The following is a description of a gene set: Stromal cell lines represent an exceptional tool to study the role on the microenvironment on hematopoietic stem cell (HSC) activity. We have compared the expression profile of HSC supportive vs non-supportive stromal lines generated from different hematopoietic tissues in the mouse, i.e the aorta-gonad-mesonephros (AGM) region, the fetal liver and the adult bone marrow, sequentially activated during development. In this study, six stromal lines were used with one HSC supportive and one non-supportive for each tissue (triplicate samples for each stromal line). We used Mouse Gene 1.0 ST microrrays in combination with GSEA and statistical analysis to identify lists of genes that segregate HSC supportive from non-supportive stromal lines. Genes up-regulated in the HSC supportive stromal cell lines. species: Mus musculus Mouse Gene Set: DURAND_STROMA_S_UP, and this is the list of marker genes: Adam8, Pdgfrb, Nrbp2, Ndrg1, Elfn1, Gas2, Npr3, Fam20a, Rnf150, Taf9b, Col3a1, Ltbp2, Depdc7, St3gal1, Cdkn2b, Sema3f, Nynrin, Adam12, Hspb8, Oasl1, Lpar4, Speg, Mmp15, Pxylp1, Col4a6, Dtx3l, 1700048O20Rik, Prrg1, Oxr1, Six1, Plekha2, Ctsh, Mmp23, Fabp7, Ivd, Lrig3, Stat1 (NCBI Gene Id 98183), Nxf3, Dync2i1, Pmvk, Il1r1, Gria3, Htra3, Car5b, Maged2, En1, Tiaf2, Serpinb6b, Tcf7l1 (transcription factor 7 like 1 (T cell specific, HMG box)), Bmper, Pde4d, Eif4e3, Mtss2, Rtp4, Ago4, Itgb3bp, Rbpms2, Lrp11, Osmr, Lhx9, Plekhg4, Pde1b, Chst1, Jak3, Smoc2, Rhobtb1, Galnt13, Plxna2, Il1rl1, Il15, Phospho1, Col6a2, Hoxc8, Syn1, Lrrc4c, Arhgef6, Mn1, Slc4a4, Fut8, Calcrl, Adgrl2, Duoxa1, Ubash3b, Slc43a1, Tfap2a, Porcn, Sulf2, Cdyl2, Gata3, Fam110b, Fzd1, Hoxb13, Ust, Rtkn2, Sox5, Inpp4b, Mest, Plxnd1, St6galnac2, Epn3, Ly6f, Zc2hc1a, Arhgef28, Ell2, Efna5, A4galt, Cyp26b1, B4galnt1, Mid2, Snai2, Ccn5, Cdkn1c, Zdhhc15, Sorcs2, Rac3, Notch4, Ptprf, Fgf10, Coro2a, Selenop, Ptn, Kbtbd7, Car13, Eda, Scn1b, Nes, Morc4, Lonrf3, Oasl2, Fzd8, Nudt14, Prkd1, St6gal1, Klra6, Atp10a, Gm57857, Dock3, Arc, Tbx20, Rb1cc1, Slc37a2, Capn6, Col1a1, Pear1, Pdlim4, Col1a2, Angel1, Tnfrsf23, Hykk, Myo1d, Prune2, Inf2, Emb, Dynap, Jup, Adamts2, Castor1, Dclk2, Onecut2, Rab3il1, Il18rap, Ifit1, Adam19, Rps6ka6, Rgs4, Tmem121, Plpp3, Lgalsl, Pde1a, Lamtor4, Rorb, Chst2, Ccdc80, Niban1, Fyb1, Itm2a, Cxcl12, Cd248, Zfp618, Medag, Tmem47, Il13ra1, Btbd2, Cyp2j6, Plpp1 (phospholipid phosphatase 1), Ppp1r13b, Aoc3, Hcn2, Fabp4, Mmp2, Igf1 (insulin-like growth factor 1), Cfap20dc, Arhgap28, Matn2, Zfp639, Adamts12, Mrgprf, Tmeff2, Srpx2, Nfatc1, Postn, Glrx (glutaredoxin), Nid2, Tspan7, Pax9, Nadk2, Pappa, Ctso, Cdk18, Kcna4, Bach2, Pmp22 (peripheral myelin protein 22), Kitl, Dhrs7, Cep170b, Tsc22d3, Sp8, Tex15, Rassf2, Zfp518a, Pygo1, Slfn9, Dpysl3, Pakap (NCBI Gene Id 97198), Nckap5, Gstt3, Lgmn, Nova1 (NOVA alternative splicing regulator 1), Kirrel3, Ralgapa1, Fbln1, Alpl, Adcy3, Ehd3, Ptx3, Ahr, Npr2, Pdgfra, Crip2, Loxl1, Ccl5, Popdc3, Trim21, Spon2, Plagl1, Serpinf1 (serine (or cysteine) peptidase inhibitor, clade F, member 1), Ly6a, Thsd7a, Ccl7, Slc39a8, Prkar1b, Maf, Cib2, Il4ra, Creb3l1, Pbxip1, Tram1l1, Tgfbi, Podxl, Pdk4, Lpar1, Tspan6, Mogat2, Arrb1, E130311K13Rik, Sdc3 (NCBI Gene Id 20970), Marcks, Ncam1, Map9, Angptl4 (angiopoietin-like 4), Zfp709, Rtn4rl1, Selp, Rspo2, Tvp23a, Csgalnact1, Crabp1, Akap6, Fgfr2, Cldn1, Sfrp2 (NCBI Gene Id 99743), B3galnt1, S1pr1, Cables1, Ube2l6, Serpinb1a, Pxmp4, Ebf3, Gnao1, Slc27a3, Casp12, Cbr2, Eya4, Zdhhc2, H2-DMa, Ndrg2, Ifi27, S100a16, Pcdhb22, Spp1, Slc1a3, Lpl, Fat4, Wnt10b, Tmem117, Ror2, Nck2, Svep1, Gper1